The following is a description of a gene set: Human Gene Set: GOBP_CERAMIDE_BIOSYNTHETIC_PROCESS studied in species Homo sapiens The chemical reactions and pathways resulting in the formation of ceramides, any N-acylated sphingoid., and this is the list of marker genes: CERS2, B4GALT3, ST3GAL5, CCN1, ST3GAL2, ORMDL1, CLN8, AGK, PNPLA1, ST6GALNAC3, B3GALT1, SMPD4, SPTLC2, SPHK1, B4GALT4, SPTSSA, B4GALT6, SIRT3, PRKCD, PAQR4, TLCD3B, SPTSSB, GBA1, DEGS2, CERS4, PRKAA1, ASAH2, ST6GALNAC6, ALOXE3, ELOVL1, SGMS1, B4GALT5, ST3GAL1, SPHK2, PLA2G6, CERS1, ST3GAL3, P2RX1, ST6GALNAC4, P2RX7, CERS3, ORMDL2, ENPP7, ORMDL3, C20orf173, ST8SIA6, ST6GALNAC5, CERS6, UGCG, CERS5, ASAH1, ALOX12B, FA2H, SPTLC1, ST8SIA3, ST8SIA2, B3GALT2, SMPD2, SAMD8, DEGS1, SPTLC3, SGMS2, CYP4F22, GAL3ST1, ZNF750, ST8SIA4, B3GALT4, UGT8, B4GALNT1, MECR, SMPD1